The following is a description of a gene set: Human Gene Set: CHEOK_RESPONSE_TO_MERCAPTOPURINE_AND_HD_MTX_UP To elucidate the genomics of cellular responses to cancer treatment, we analyzed the expression of over 9,600 human genes in acute lymphoblastic leukemia cells before and after in vivo treatment with methotrexate and mercaptopurine given alone or in combination. Based on changes in gene expression, we identified genes that accurately discriminated among the four treatments. Discriminating genes included those involved in apoptosis, mismatch repair, cell cycle control and stress response. Only 14% of genes that changed when these medications were given as single agents also changed when they were given together. These data indicate that lymphoid leukemia cells of different molecular subtypes share common pathways of genomic response to the same treatment, that changes in gene expression are treatment-specific and that gene expression can illuminate differences in cellular response to drug combinations versus single agents. from publication Cheok MH, Yang W, Pui CH, Downing JR, Cheng C, Naeve CW, Relling MV, Evans WE (PMID 12704389) Genes specifically up-regulated in pediatric acute lymphoblastic leukemia (ALL) patients by mercaptopurine and high dose methotrexate (HDMTX). studied in species Homo sapiens, and this is the list of marker genes: POLR3C, PTPRG, PIK3R3, PLS1, TERF1